The following is a description of a gene set: Toll like receptors (TLRs) sense microbial products and initiate adaptive immune responses by activating dendritic cells (DCs). Since pathogens may contain several agonists we asked whether different TLRs may synergize in DC activation. We report that in human and mouse DC TLR3 or TLR4 potently synergize with TLR7, TLR8 or TLR9 in the induction of selected cytokine genes. Upon synergistic stimulation, IL-12, IL-23 and Delta-4 are induced at levels 50-100 fold higher than those induced by optimal concentrations of single agonists, leading to enhanced and sustained TH1 polarizing capacity. Using microarray analysis we show that only 1.5% of the transcripts induced by single TLR agonists are synergistically regulated by combinations of TLR4 and TLR8 agonists. These results identify a combinatorial code by which DCs discriminate pathogens and provide (suggest) a rationale to design adjuvants for TH1 responses. Series_overall_design: 3 untreated, 3 treated with LPS at 2h, 3 treated with LPS at 8h, 3 treated with R848 at 2h, 3 treated with R848 at 8h, 3 treated with LPS + R848 at 2h, 3 treated with LPS + R848 at 8h Human Gene Set: GSE2706_UNSTIM_VS_2H_LPS_DC_UP species: Homo sapiens Genes up-regulated in comparison of unstimulated dendritic cells (DC) at 0 h versus DCs stimulated with LPS (TLR4 agonist) for 2 h. from publication Napolitani G, Rinaldi A, Bertoni F, Sallusto F, Lanzavecchia A (PMID 15995707), and this is the list of marker genes: ANKRD13D, ZNF473, KCTD7, TSC22D3, ZFP69, MTNAP1, ELOA-AS1, WDCP, AGAP4, SNHG1, PDCD7, GIMAP8, RWDD2B, ZSCAN29, CEP295, ZNF367, ACBD6, PRKAB2, IGIP, CCN4, ZNF439, ZSCAN26, ZNF567, GPR155, FOXQ1, SCYL3, RNF25 (NCBI Gene Id 79103), NUDT16-DT, NUP210L, EDRF1, CDKN1B, CCDC107, FADD, ZKSCAN1, RPUSD2, PLGLB2, ZNF397, ZNF791, PUS3, PEX13, ZIK1, RBAK, POLR1C, CCDC112, INKA2, NPFF, LINC01968, PHF23, CRAMP1, ZBTB41, POLK, WDR25, PGS1, RAD9A, PHETA2, GOLGA2P5, RUFY2, FOXJ1, ENSG00000259697 (novel transcript), ZNF689, ZNF805, YEATS2, SNX32, GPR20, TBX19, FRAT1, PHB1P19 (NCBI Gene Id 494150), ZNF184, SRSF1, ZNF232 (zinc finger protein 232), ZNF823, NR2F6, ZNF34, TRMT12 (NCBI Gene Id 55039), WDR74, IQCF3, PTPRN, FEV, LINC00494, ZNF281, PAPOLG, LINC00964, TXLNGY, NRDE2, UNC119B, EML5, C11orf87, NLRC4, ZNF555, FRAT2, UTP25, MED9, TRBV24-1, LUZP4, ZNF564, DDX51, ZNF432, ESCO2, CDC42BPG, KIAA1210, ZNF302, VPS37A, OR52K3P, SOX30, SETDB1, TSPAN12, HHEX, TMEM223, ZNF493, LINC00324, CACNA2D4, FDX2, NFE2 (nuclear factor, erythroid 2), MTRFR, ETAA1, ZNF354A, RPL32P3, LINC00102, ZNF574, ZNF692, ASTN2, ZNF813, ZNF398, NEURL1B, YAE1, ZNF606, OVOL2, ZNF224, CROCCP3, CBFA2T2, ZNF879, ASTE1, BTBD8, RSRP1, ZNF844, PLD6, LRR1, ZNF671, MTFR2 (mitochondrial fission regulator 2), HCFC2, DOK1, ZNF268, ZNF641, TIMM29, C1orf50, ENO2, ZBTB26, C14orf93, ZFP82, SMIM17, NBPF1, GIMAP7, ZNF862, ZNF284, DUSP7, RTN4RL1, WDR24, CFAP74, ARL14EP, SP2-AS1, ZNF322, HINFP, ZNF7, IER5L (NCBI Gene Id 445576), ZFP62, ABHD17B, TIMM22, PARS2, ZNF615, BBS12, NEURL4, SIGLEC11, CCR2 (C-C motif chemokine receptor 2), ZNF23, DZIP3, NAGS (N-acetylglutamate synthase), ZNF18, ZKSCAN4, RIOX2, ELAC1, DCLRE1C (NCBI Gene Id 64421), ZNF581, RPS2P45, NHLRC2, LINC00942, ZNF449, ZNF260, GRPEL2, IFNA8, NAPEPLD, PHF12, ASPHD2, ZNF324, XKR6 (NCBI Gene Id 83654), LYRM7, NSUN5P2, ZCCHC3